The following is a description of a gene set: studied in species Mus musculus Mouse Gene Set: GOBP_REGULATION_OF_SENSORY_PERCEPTION Any process that modulates the frequency, rate or extent of sensory perception, the series of events required for an organism to receive a sensory stimulus, convert it to a molecular signal, and recognize and characterize the signal., and this is the list of marker genes: Tac4, Tafa4, Ccl3, Nmu, Acp3, Atpsckmt, F2r, Nmur2, Grm1, Zfhx2, Smr3a, Grm3, Grin2d, Ccn3, Cacnb3, Tac1, Abcb1a, Mgll, Fabp5, Smr2, Tmem100, Spx, Adora1 (adenosine A1 receptor), Smr2l, Gpr171, Pirt